Given this list of marker genes WDR54, LRATD1, ERF, CCDC34, HPCAL4, KCNMB3, ELAPOR1, ST13P4, AP1S1, TBC1D20, MAPK10, SPAG8, SCUBE3, EMC10, GPN1, DOC2A, JOSD2, PTPDC1 (NCBI Gene Id 138639), CERS1, TBPL1, CRYAB, CCDC148, ADISSP, MYCBP (NCBI Gene Id 26292), C22orf15, CCDC121, GALNT2, ODC1, MLEC, RAPGEFL1, TIMM21, DAGLA, OXNAD1, MTF1, SKIL, JUN, UBL4B, CFAP36, MTX1, HBP1, CABS1, CTAGE1, CAMK2A, TM4SF4, FIS1, PKP4, RARG, THADA, PBXIP1, CASZ1, PGS1, EPG5, CCDC102A, YBX1, COX8A, CIPC, SEM1 (NCBI Gene Id 7979), SRSF6, GON7, PPM1E, RING1, STOML2, DPH3, FBXO15, GMPPB, DAAM1 (NCBI Gene Id 23002), HOXB6, H1-10, TP53BP1, PNMA8A, C10orf67, TSPAN5, NLGN3, SIK2, RRAD, ID1, SIX6, HSPB2, ETS2, WNT4, ATP1A3, PHC1, NUP153, TPPP3, TAOK2, RRAGB, AZIN1, LMNTD1 (lamin tail domain containing 1), CFAP107, HOXA2, SLC37A1, RIPOR1, THBS3, MRPS10, EHBP1, RNF213, CSMD3, DNAH12, JMJD1C, CARF, TEX26, METRN, SALL1, LINC01973, DCX, SLC35A1, STX8, TUBA1A, TMIE, NDUFAF3, GDF1, ODF2, PHTF1 (NCBI Gene Id 10745), UBR7, NDST1, CFAP52, SULT2A1, ZNF287, PANK2, RNF10, here is a description of the gene set: Genes having at least one occurrence of the highly conserved motif M98 GTCNYYATGR in the regions spanning 4 kb centered on their transcription starting sites. The motif does not match any known transcription factor binding site. Comprehensive identification of all functional elements encoded in the human genome is a fundamental need in biomedical research. Here, we present a comparative analysis of the human, mouse, rat and dog genomes to create a systematic catalogue of common regulatory motifs in promoters and 3' untranslated regions (3' UTRs). The promoter analysis yields 174 candidate motifs, including most previously known transcription-factor binding sites and 105 new motifs. The 3'-UTR analysis yields 106 motifs likely to be involved in post-transcriptional regulation. Nearly one-half are associated with microRNAs (miRNAs), leading to the discovery of many new miRNA genes and their likely target genes. Our results suggest that previous estimates of the number of human miRNA genes were low, and that miRNAs regulate at least 20% of human genes. The overall results provide a systematic view of gene regulation in the human, which will be refined as additional mammalian genomes become available. studied in species Homo sapiens Human Gene Set: GTCNYYATGR_UNKNOWN from publication Xie X, Lu J, Kulbokas EJ, Golub TR, Mootha V, Lindblad-Toh K, Lander ES, Kellis M (PMID 15735639)